The following is a description of a gene set: studied in species Homo sapiens Human Ca2+/calmodulin-dependent phosphodiesterase PDE1 is activated by the binding of calmodulin in the presence of Ca(2+). PDE1 has three subtypes PDE1A, PDE1B and PDE1C and their role is to hydrolyze both cGMP and cAMP. Their role is to antagonize the increased concentration of the intracellular second messengers determined by the synthetic activity of the adenylate cyclase enzymes thus governing intracellular cAMP dynamics in response to changes in the cytosolic Ca2+ concentration. PDE1 are mainly cytosolic but different isoforms are expressed in different tissues. Reactome Pathway: Cam-PDE 1 activation part of: Calmodulin induced events, and this is the list of marker genes: PDE1B, PDE1C, PDE1A, CALM1